Given this list of marker genes ETS1, OTUB2, MCM8, VPS18, H3-3A, TYRP1, HBP1, DDX3Y, ZNF845, MAP3K7, MEIS1, TRIP13, WWC1, PCDHA3, IKBKE, CDC42EP4, DET1, RPS6KA3, MAP3K10, SGK3, PCDHA1, PPM1D, DNAJB1, DYNC1I1, ZNF431, CBL, EYA2, KDM2A, TRAM1, PCDHA2, STXBP5L, ENTPD5, PCDHA5, ARID2, CSNK1G2, MPEG1, NARS1 (NCBI Gene Id 9243), E2F2, IKBIP, RUFY2, ACTL7A, VAV3, LRRC8B, RBP2, PDLIM5, MED21, SP1, ZNF652, WEE1, AKTIP, LRRTM2, GALT, AHRR, ZMYM2, AICDA, TRIM32, GABARAPL1, UBXN8, BOC, TBR1, ZBTB38, ZBTB41, USP9X, BNC2, PICALM, RICTOR, ZNF492, OOEP, RC3H2, TENM3, JARID2, SPRTN, WBP1L, TPRKB, STRN3, UBQLN1, PCDHA9, DIPK1A, LSM14A, CLCN3 (NCBI Gene Id 133073), TLE4, CTTNBP2NL, KANSL1, ZC2HC1B, DPY19L1, GPM6B, TRIP11, SEC14L5, RELA, ZSCAN12, PLEKHA1, C2orf80, FBXO33, CSF1R, BTN2A2, SOCS1, SESTD1, GABRA1, GLUL, OLFML3 (olfactomedin like 3), SMAD2, RAB11FIP2, MYB, HIVEP2, MYBL1, ATP2C1, FXR1, PATJ, FAR1, ANKFY1, CARD10, INTS6, PCDHAC2 (protocadherin alpha subfamily C, 2), RPS6KA5, SMARCA4 (SWI/SNF related, matrix associated, actin dependent regulator of chromatin, subfamily a, member 4), PCDHA4, RPS6KB1, TP53INP1, ZPLD1, KLHL4 (NCBI Gene Id 56062), RREB1 (NCBI Gene Id 6239), PCDHA10, CDX1, ARVCF, TDRD9, ZDHHC20, G2E3 (G2/M-phase specific E3 ubiquitin protein ligase), SCG2, PAK5, ZIC3, FBXL17, ZNF761, VMA21, ZKSCAN5, PIWIL3, DMAC1, SATB1, FMNL2, ZNF98, CAB39, SARAF, PCDHA6, MAP4K3, ATXN1L, PCDHA12, C10orf90, MEF2A, TRPM8, PALD1, JADE1, WDR72, CHAF1A, TAB2, PSIP1, PCDHA11, RCOR1, MYO1D, SCUBE2, DCUN1D3 (NCBI Gene Id 123879), ASAP2, ZNF860, SERPINA10, FBXO48, TWF1, S1PR1, CEBPB, TRPS1, MARCHF1, PTPRJ, CNOT7, ACTA1, IL6R, PCDHA13, GJA5, BACH1, MAP3K14, PCDHA8 (protocadherin alpha 8), LCORL, C1GALT1, TTC21B, TSHZ3, RAPGEF2, PCDHAC1, TRAF3 (TNF receptor associated factor 3), KDM5B, DHX40, MITF, CSRNP2, PCDHA7, USH2A, IRF2BP2, REDIC1, MBTD1, C8orf44-SGK3, SALL1, GYG1 (glycogenin 1), PTPN2, UNC80, KRAS, HNRNPA3, FGF7, ARL6IP5, TCF7L2, FAM135A, MED13L, RBMS3, LDLRAD3, MYO10, BSDC1, GDPD1, RCN2, TAPT1, DYRK2, MIDN, SEMA5A, RGP1, CYB561D1, ANTXR2, EHD1, LAT2, CD36, VPS36, FAM199X, FOS, KLF3, LRIF1, PLEKHB2, CACUL1, CARD11, ZNF236, ECSCR, LRRC59, SMUG1, here is a description of the gene set: Genes predicted to be targets of miRBase v22 microRNA hsa-miR-155-5p in miRDB v6.0 with MirTarget v4 prediction scores > 80 (high confidence targets). from publication Chen Y, Wang X (PMID 31504780) Human Gene Set: MIR155_5P studied in species Homo sapiens